The following is a description of a gene set: studied in species Homo sapiens Human Gene Set: MIR664B_3P Genes predicted to be targets of miRBase v22 microRNA hsa-miR-664b-3p in miRDB v6.0 with MirTarget v4 prediction scores > 80 (high confidence targets). from publication Chen Y, Wang X (PMID 31504780), and this is the list of marker genes: CHM, TMEM45A, PHIP, OXR1, UGT3A1, SRP19, C2orf88 (chromosome 2 open reading frame 88), NCK1, YIPF6, FAM83B, MAMDC2, STMN3, IL6ST, PHACTR2 (phosphatase and actin regulator 2), FNIP1, INSYN2A, IGSF11, CLVS2, RBFOX1, SPIRE1, CDK6, DSC3, EMC6, KIAA1549L (NCBI Gene Id 25758), TBL1XR1, CEP57L1, LIF, ROBO2, NUS1, CCAR1, PFDN4, LCP2, TEAD1, CFAP91 (NCBI Gene Id 89876), PAPOLG, DCAF10, ARHGAP28, FAM98B, DPP8, MYEF2, MEGF11, PIK3CA, DMGDH, SLITRK4 (SLIT and NTRK like family member 4), ITGA4, ZIC3, ING1, ZBTB4, GXYLT1, SULT1B1, GNAT1, BRCC3, SLITRK2, GPC6, SHC3, FAM210A (family with sequence similarity 210 member A), SORD, BMPR1A, LSM8, SWT1, KCNN3, SMIM14, RABGEF1, TMEM220, USP7, SPTLC3, GNAQ, DENND4A, HSPA4L, PLAC8 (NCBI Gene Id 95621), MOB1B, FBXO33, KICS2, C4orf17, APC, ABI2, RASGRF2, OMG, DGKE, ATP8A1, ZFHX3, FBXO21 (F-box protein 21), SETX, ZFP14 (NCBI Gene Id 57677), MBNL3, UBL3, PTPDC1, PRTG, DNAJB14, PHKB (NCBI Gene Id 5257), GPR34, OSBPL8, PRKCB, PSMD12, MAP1B, KRT10-AS1, TMEM229A, KLF7, KRTAP4-2, STT3A, PHLDB2, SLC22A12, ELL2, YPEL1, CD1B, LRAT, WWC2, MAP4K5 (NCBI Gene Id 11183), GSKIP, APBB2, RAP1A, SH3GL3, ITPR1, HHIPL2, MYO6, PAK3, MAP3K13, USH2A, ERAP1, QKI, DISC1, DENND4C, GPBP1, BCL11B, GJA1, ANO5, UBE4A, NEDD4L, EPHA3, KIF4A, ARRB1, POLR2M, CHRNA9, KIF5B, CTDSPL2, HBS1L, TMEM30B, CHSY3, CADM2, ETV6, PATJ, CAMTA1, SKIL, BICRAL, RHOQ, IL22RA1 (NCBI Gene Id 58985), CWF19L1 (NCBI Gene Id 55280), F5, CUL4B, SMIM8, SPA17 (sperm autoantigenic protein 17), LRP6, GPRASP2, ZBTB34 (zinc finger and BTB domain containing 34), CDH10, RMND5A, MBOAT2, PGM2L1, WWTR1, RIOK2 (NCBI Gene Id 55781), CLDN8, C2CD5, NOVA1, MKX, FZD3, SH2D4B, RAB3B, CSDE1, GPR180, VPS50, LTBP1 (NCBI Gene Id 4052), HOXD10, PCDHA2, UFL1, PPFIA1, PDP1, ZNF713, NCEH1, GDPD2, DOCK1, MC2R, NANOG, GPHN, MAP3K7, NTRK2, SELENOF, BECN1, TBC1D4, ITGBL1, LDAH, APAF1, ZBTB10, LSAMP, HOOK3, SLC25A16, TMEM200A (NCBI Gene Id 114801), DEPDC1, SIRT1, SLC6A11, TMEM215, LRRTM2, NTM, LAPTM5, SLC4A4, COL4A3, ATE1, NR2F2, AQP4, SSPN, SLC16A7, HDAC9, POC1B, OGFRL1, NDFIP2, GPR160, ENTPD7, LGI1, MTDH, CACNB4, JRKL, ALCAM, HSD17B12, DIO2, HAS2, TAOK1, SAMTOR, OLFML2B (NCBI Gene Id 25903), STXBP5, PPFIA2, RPRD1B, DLG2, CD2AP, MBTD1, SRBD1, CCSER1, GNAS, PRSS37, CNTN5, SUMF1, TPR, ZYG11A, ATP2C1, NAALADL2, PDIK1L, FRYL, CMTM4, SLC10A2, KLF9, SENP6, FAM76B, KLHL31, IPO7, GLDN, OSBPL6, OXNAD1, RAB23, WDR89, TBC1D9, PPM1L, SEC24B, PCDH18, ERAP2, XKR6, GOPC, HEY2, TMEM62, CDC73, ZNRF3, AGFG1, HNMT, SLC7A13, GLIS3, CAV2, GLS, ETNK1, NAA15, NPY5R, TANC2, ZNF655, DNAI2, OGT, NPAS3, JAG2, PPP1CC, ADAM22, AHCTF1, SAMD13, TBX22, ANKRD44, GUCY1A2, TNFSF8, SHLD2, MDGA2, CPT1A, ZFX, ANKRD10, INSYN1, PRP4K, IPO9, IKZF5, ZMYM4, PYGO1, CLEC12B, ELP4, BACH2, PRICKLE2, COBLL1, SNAP25, ARL5A, DGKH, POU3F2, PTCHD4, GPM6B, TMF1, HSF5, ANTXR2, KCNH8, ZNF326, CCNC, GPRASP3, TMED4, DBT, CMC4, SOBP, DHX8, PHC1, CNTNAP4, KCNQ3, PIAS2, B3GNT5, C1orf141, AFF2 (ALF transcription elongation factor 2), ANGPT1, MYRIP, CAPN7, CLIC5, B4GALT6, LIMS1, YTHDC2, CAVIN4, CTCFL, MBTPS2, PNPLA8, ACSL6, TMEM233, THSD7A, SORBS1, HDAC8, AK3, PPP2R3A, TRABD2B, TMTC3, MED4, LRRTM3, CRISPLD1, NFIB, SERINC1, MAEA, GIPC2, EAF1, ZC3H6, IQGAP2, ATAD1, ZNF704, MFSD6, SMIM15, LONRF1, FUT9, RAB27B, PTCHD1, SLC6A2, NEXMIF, GCOM1, MORN4, ACVR2A, UQCC4 (ubiquinol-cytochrome c reductase complex assembly factor 4), ZNF280C, ERP44, MCTS1, TMX4, GABPA, PRDM10, KLF5, STAM, RUFY2, LSM11, CHODL, CTTNBP2NL, SYPL1, UVRAG, SLC7A11, NECTIN3, NARS1, PLEKHA3, ATP6V1C2, RPS6KA3, GABRB2, KIF2A, LACTB2 (NCBI Gene Id 51110), ZNF605, CCSAP, PHB1, FNDC3A (fibronectin type III domain containing 3A), PHF20L1, LINC03042, OTUD6B, NTNG1, ANGEL2, STAG2, PJA2 (praja ring finger ubiquitin ligase 2), CFAP90, CTNNAL1, PANK1, PIK3R1, SEM1, NCOA7, TMEM135, CREG2, MMRN1, NET1, FAT3, CALN1, AJUBA, C19orf12, SNTB2, YTHDF3 (NCBI Gene Id 253943), EIF3J (eukaryotic translation initiation factor 3 subunit J), SLC48A1, DAPP1 (NCBI Gene Id 27071), ACTN2, ZFHX4 (NCBI Gene Id 79776, zinc finger homeobox 4), OLIG3, TULP4, YOD1, RAB22A, NVL, ARMT1, PRPS1, DSCAML1, SRP72, HIPK2, WASHC5, PARM1 (NCBI Gene Id 25849), VGLL3, SRGAP1, NAPEPLD, ARSB, CD38, BZW1, SH3TC2, NCOA5, CAPZA1, DIP2C, SPC24, ANKRD27, CPLX4, CTNNA1, MDH1, USP38, ACBD5, IRF8, KLHL9, ANKIB1, SLC25A17, SFI1, IGSF5, STAG1, TIGAR, TMSB4X, CALM1, PRELID3B (PRELI domain containing 3B), KLF12, NR4A3 (nuclear receptor subfamily 4 group A member 3), LAMP3, SGIP1, ANO10, GYPA, DCP2, METTL14, LRATD1, SQLE, SHROOM3, KIF11, NKTR, PABIR2, QSER1, PKN2, RIF1, LRRC19, ZNF347, STMN2, LRRK2, AHSA2P, GPC4, SLCO1A2, AP1S2, TENT5A, PTGER3, HABP4, OR51E2, NCKAP5, TTC17, NSUN6